Given this list of marker genes Setd1a, Smyd2, Smyd3, Smyd1, Kmt2a (lysine (K)-specific methyltransferase 2A), Setd1b, Kmt2d, Prdm9, Kmt2c, Kmt2b, here is a description of the gene set: Mouse Gene Set: GOMF_HISTONE_H3K4_TRIMETHYLTRANSFERASE_ACTIVITY Catalysis of the reaction: L-lysyl4- + 3 S-adenosyl-L-methionine = 2 H+ + N6,N6-trimethyl-L-lysyl4- + 3 S-adenosyl-L-homocysteine. This reaction is the successive addition of three methyl groups to the unmethylated lysine residue at position 4 of histone H3, producing histone H3K4me3. studied in species Mus musculus